Given this list of marker genes IPMK, CFAP418, CHCHD7, TAB2, CNTN4, PTBP2, ZFAND4, CTTNBP2, ATXN3, MPHOSPH9, MECP2, DENND4C, KCNC1, RSBN1, EPC1, TOP2A, ZCCHC10, NR3C2, N4BP2L1, MAFB, ALKBH5, ENTPD1, PBX2, FTO, FNIP2, PRRC1, ERBIN, GADD45A, TRMT5, LEPROT, DTD2, BMPR2, HACE1, G3BP2, EZR, MAP3K2, ADH5, TFRC (NCBI Gene Id 7037), FLI1, DR1, CFHR5, LRRTM3, HCFC2 (host cell factor C2), ZFYVE28, ELAVL1, TMEM245, SPINK7, CSDE1, CDK13, ENPP2, FERMT2, TCF20, TRAPPC1, SLC25A36, ESYT2, GFRA1, EVI5, USP33, KANSL1, SRCIN1, TSPAN2, SREK1, IQCJ-SCHIP1, ACVR1C, PCBP4, GNS, MACF1, GPR137B, SGCZ, DGKH, BOLL, UGGT1, MCC (NCBI Gene Id 4163), JAKMIP2, PNPLA4, QKI, SLC4A10, PDE10A (phosphodiesterase 10A), CPNE3 (copine 3), STRBP, PPP3R1, B4GALT6, PCGF3, FZD3, MAP4, GABPB1, ZNF260, PIAS1, GTF2A1, TP53INP1, FOXO3, ADAM10, EHMT1, RAPH1, GPAM, C4orf51, MYO5A, MED4, ZNF148, TTC39B, CLASP2, HERC1, ABHD6 (abhydrolase domain containing 6, acylglycerol lipase), SCAI (NCBI Gene Id 286205), CHST14, SLCO4C1, NFAT5, CD47, WDR17, SLC25A24, SOWAHC, UGT3A1, SKIL, FAM149B1, CNBP, NRK, RBFOX1, SLC6A11, INO80D, SOX9, ONECUT2, SLC44A5, PIK3R3, KMT2D, TMEM236, MIER3, ZPLD1, NNT, EIF4E, USP31, ANKRD55, PI4KB, GNAQ, DMD, PPM1D, U2SURP, ADAMTS5, NAV3, TM9SF2, HTR5A, RAB31, TLNRD1, TAOK1, STXBP5, NEMF, TMEM33 (transmembrane protein 33), VPS37A, TNRC6B, CAMTA1, IFT81, ZNF681, ZYG11B, TMED7, ZFPM2, GPR22, FOXJ3, SPOPL, PAK2, MSI1, UQCC6, COX15, USP38 (ubiquitin specific peptidase 38), CDC14A, CDK6, ETNK1, CAVIN4, BCOR, ZNF658, XRN2, SPIRE1, GPC4, TPR, SYNDIG1L, SP3, GNB2 (NCBI Gene Id 96628), APELA, TRPM7, STAM2, TDG, TBL1XR1, P3R3URF-PIK3R3, FBXO22, SLC4A4 (solute carrier family 4 member 4), ZFX, NHLRC2, VEZT, SPRED1 (sprouty related EVH1 domain containing 1), RPS6KB1, ZC3H12C, PGM2L1, CSTF3, ZNF484, ANGEL2 (NCBI Gene Id 90806), TEAD1, CXXC4, EIF1, ITPRID2, TENT4B, SRSF11, TAF9B, RNF207, SPIN4, EDEM3, PHIP, GRIA3, GTF2IRD2B, PARP16, LUC7L2, TTPA, SDE2, PRKAR1A (NCBI Gene Id 5573), HS3ST3A1, SEC62, ANKRD11, HYPK, VPS13C, ZNF275, NDUFC2-KCTD14, SLC2A13, ATXN1, PHF20L1, DIDO1 (death inducer-obliterator 1), PPM1B, HAPLN1, ZDHHC21 (zinc finger DHHC-type palmitoyltransferase 21), CCAR1, TP53BP1, RPGRIP1L, WAPL, NF1, TMED4, TXNRD1, THUMPD1, BBS5, COMMD3-BMI1, TOP2B, REST, MEX3D, EBF2, TNPO1, ENOPH1, SERTAD2, PAIP1, WASF1, SCML1, DDX3X, B3GAT1, NUDT12, KLF9, PMS1, PTEN, ZMYND19, ATF7IP2, PTPN12, PAG1, WDR47, ZFR, DNAJC27, MMP2, IKZF2, PLEKHB2, RPP30, INTS15, PIK3CB, KANSL1L, LTBP1, TRMT10A (tRNA methyltransferase 10A), ADAMTSL3, PHF6, PSIP1, PCDH11X, TRAPPC8, MTX3, IKBIP, FBXW7, PHF3, ZDBF2, ARPP19, ATL1, ATXN7, ZNF711, HLTF, OSBPL8, KLHL8, MAP7, SOCS6 (NCBI Gene Id 9306), AMPH, CUL3, PLPPR1, WDTC1, HACD3, NEURL3, HECTD2, USP48, CALM1, PLCH1, ADAM22, RAPGEF5, ZNF229, OPRM1, BRWD3, MINDY2, TSTD2, TPBG, ZNF264, PIKFYVE (NCBI Gene Id 387568), INHBB, ZFHX3, PIK3R1, RGS3, TNRC18, RNF168, ATF2, ELK4, MYEF2, SCHIP1, B3GLCT (NCBI Gene Id 145173), MMAB, CREB5, GNAO1, KLHL28, RAD23A, MEX3C, XPO4, SMNDC1, NEK7, ATP2A2, ST18, PCBP1, CXCR4, LYRM7, ARID4A, PCDH7, CPNE8, PEX13, PIP4K2A, JAKMIP3 (Janus kinase and microtubule interacting protein 3), CCDC186 (NCBI Gene Id 55088, coiled-coil domain containing 186), PAPOLA, ZNF569, GABRG1, DSG2, ZNF333, SNRPD1, GUCY1B1, ADIPOQ, KLHL15, RAD51AP1, POU4F1, VMA21, MPZL2, PIK3CG, AFG2A, SERINC5, PABPC5, RNF19A, CCNYL1, PPP6R3, MYO1B, ADGRB3, ACVR2B, MTF1, TRUB1, STK39, TET1, UBR2, ATRX, TMEM169, BRWD1, LINC02801, GPR63, RNF2, CNOT6L, GALNT1, VASP, ACYP2, CDC42BPB, ARHGAP21, FZD4, WASHC3, SGIP1, GEMIN2, LPP, TET2, UBE2G1, ZEB1, BEX2, TSPAN16, PDS5B, PTBP3, OSM, ZNF713, DCC, LATS1, GKAP1, SERBP1, PLAGL1, SAMD8, UTP23, ZBTB20, ZNF281, ATP11C, EGFL8, CSRNP3, CELSR1, MSL2, KIF2A, BMI1, GUCY1A1, DKK3, RNPS1, PURB, HERC4 (NCBI Gene Id 63907), RNF38, NSD2, ALS2, CDCA4, GEMIN5, DSC2, PDE7B, SLC1A3, IREB2, ZBTB44, SV2B (synaptic vesicle glycoprotein 2B), ADPRH, OTULINL, ACKR3, SLC26A4 (solute carrier family 26 member 4), SMAD4, CENPH (centromere protein H), TGFBR3, OTUD6B, CALB1, TBP, SESN3, MFAP3L, GCSAML, ITGAV, C1orf131, ATRNL1, ZNF91, ZFHX4, NEXMIF, BTF3 (basic transcription factor 3), MOB1B, ARK2N, KBTBD8, SUB1, CDYL, KDELR3, PHC3, NTN4, FTHL17, SULT1C4, ARL8B, CNTNAP2, NUAK1, GTF2IRD2 (NCBI Gene Id 84163), HLF, YWHAE, FAM3C, RAB27B, PIGN, PCBP2, ZBTB14, GPR85, CCL28, OTX2, MEF2A, PCLO (NCBI Gene Id 56630), KAZN, PCGF5, ADSS2, CNEP1R1, GABRB1, DYNC1LI2, CNTN1, RUFY2, RNF14, ZBTB41, CSK, FAM76A, C3orf70, FGG, PCNA, RAB22A, ZNF280C, MED28, ARL6IP1, CEP85L, ARHGAP6, here is a description of the gene set: Genes predicted to be targets of miRBase v22 microRNA hsa-miR-548az-3p in miRDB v6.0 with MirTarget v4 prediction scores > 80 (high confidence targets). studied in species Homo sapiens from publication Chen Y, Wang X (PMID 31504780) Human Gene Set: MIR548AZ_3P